Given this list of marker genes Nudt19, Hsd17b4, Acot7, Nudt8, Nudt7, here is a description of the gene set: Mouse Gene Set: GOBP_MEDIUM_CHAIN_FATTY_ACYL_COA_METABOLIC_PROCESS studied in species Mus musculus The chemical reactions and pathways involving medium-chain fatty-acyl-CoAs, any derivative of coenzyme A in which the sulfhydryl group is in a thioester linkage with a long-chain fatty-acyl group. A medium-chain fatty acid has an aliphatic tail containing 6 to 12 carbons.